Given this list of marker genes SMC5, TERT, ZSCAN4, EME2, RAD51C, MSH2, EME1, DMC1, TERF2 (telomeric repeat binding factor 2, NCBI Gene Id 7014), TEP1, SMC6, BRCA2 (NCBI Gene Id 82716), MRE11, ERCC2, RAD54B, RAD51D, XRCC3, GEN1, RAD52, MLH1, RAD50, RAD51, MUS81, XRCC1, MSH3, ERCC1, ANKLE1, NSMCE2, ERCC4, here is a description of the gene set: Human Gene Set: GOBP_MITOTIC_RECOMBINATION studied in species Homo sapiens The exchange, reciprocal or nonreciprocal, of genetic material between one DNA molecule and a homologous DNA region that occurs during mitotic cell cycles.